Given this list of marker genes KRAS, PPP2CB, HRAS, UBA52, PPP2R1B, PPP2R5B, UBC, PPP2R1A, RAF1, UBB, PPP2R5A, BRAF, ARAF, DUSP5, NRAS, MAP2K1, RPS27A, DUSP2, BRAP, MAP2K2, DUSP10, MAPK12, DUSP4, DUSP8, MAPK1, PPP2R5E, DUSP9, KSR1, PPP2R5C, PTPN7, PAQR3, DUSP16, PTPN3, MARK3, DUSP6, DUSP1, DUSP7 (NCBI Gene Id 1849), PPP2R5D, YWHAB, MAPK3, PPP2CA, PEBP1, PPP5C, here is a description of the gene set: species: Homo sapiens Human Gene Set: REACTOME_NEGATIVE_REGULATION_OF_MAPK_PATHWAY Negative regulation of MAPK pathway